The following is a description of a gene set: Generalized weakness of the muscles of the arms and legs. species: Homo sapiens Human Gene Set: HP_GENERALIZED_WEAKNESS_OF_LIMB_MUSCLES Generalized weakness of limb muscles, and this is the list of marker genes: GFPT1, DPAGT1, ALG2, ALG14, GMPPB